Given this list of marker genes Nupr1, Foxl2, P2rx2, Mir669a-7, Akirin1, Mir669a-2, Shh, Ep300, Prkaa1, Cntnap1, Pax5, Fos, Nr2f2, Hdac4, Ppif, Mef2d, Eln, Mir669a-10, Shox2, Klf5, Ankrd2, Gpc1, Gtf3c5, Mir669a-4, Tbx1, Cyp26b1, Fxr1, Cited2, Des, Tgfb1, Rtl1, Synb, Hivep3, Nf1, Bmal1, Uqcc2, Dmrta2, Pax7, Vax1, Dag1, Myh14, Gmppa, Gm34220, Ccnt2, Vamp5, Myl6b, Rcan1, Mymx, Srpk3, Tll2, Lemd3, Bves, Notch1, Sox11, Phox2b, Cntfr, Vps54, Mylk2, Hlx, Pitx2, Bin3, Svil, B4galnt2, Myhas, Kras, Mir675 (NCBI Gene Id 735280), Ddx17, Hmg20b, Fbxo22, Asnsd1, Ldha, Lmod3, Rbfox1, Lncpint, Nr4a1, Pdlim3, Wnt10b, Psma6, Mylpf, Mapk14, Ephb1, Bcl9l, Negr1, Crhr2, Twist1, Ankrd33, Maff, Sap30, Snhg15, Casq1, Bcl9, Mir214, Atf3, Homer1, Wt1, Gata4, Met (NCBI Gene Id 194383), Popdc3, Sin3b, Emd, Dmd (NCBI Gene Id 93863), Nfix, Myl6, Xk, Cacna1s, Flot1, Mettl8, Usp19, Nras, Cdon, Smyd1, Col6a1, Rps6kb1, Fgfrl1, Scx, Gpx1, Klhl41, Nfatc3, Ddx5, Ero1a, S100b, Rb1, Nln, Hmgcr, Myom1, Pax3, Mir669a-6, Spg11, Tafazzin, Mir669a-8, Scn11a, Ybx3, Hoxd9, Cntnap2, Ppp3cb, Abcc9 (ATP-binding cassette, sub-family C member 9), Fkrp, Mcub, Hlf, Gpcpd1, Popdc2, Meox2, Dll1, Megf10, Myod1, Large1, Cdk5, Ryr1, Tcf7l2, Myt1, Asb2, Pitx1 (paired-like homeodomain transcription factor 1), Norad, Skil, Actn3, Rbm24, Lemd2, Plagl1, Snw1, Nr1d2, Cav2, Zfp689, Ppp3ca, Myc, Vgll2, Stra6, Myoz1, Msc, Btg2, Wnt3a, Selenon, Mir669a-3, Fktn, Chrnd, Igf2, Mtm1, Kat8, Myog, Cfl2, Bcl2, Ass1, Egr1, Myf5, Vrk3, Mir669a-5, Cops2, Kel, Klhl40, Flnb, Dner, Ski, Chrna1, Mettl21c, Cflar, Hspa8, Acta1, Hdac5, Myoz2, Hsd17b1 (hydroxysteroid (17-beta) dehydrogenase 1), Myorg, Myf6, Mir669a-1, Nphs1, Tcf21, Mbnl1, Foxp1, Foxp2, Barx2, Hoxd10, Adrb2, Pmp22, Ankrd1, Myocd, Egr2, Neurl1a, Hottip, Six1, Disp1, Smo, Heyl, Ctnnb1, Zbtb18, Eomes, Six4, Stac3, Med20, Foxn2, Mef2c, Cav1, Sox8, Mnx1, Hdac9, Col19a1, Plec, Mir669a-9, Meg3, Rhoa, Mstn, Usp2, here is a description of the gene set: Mouse Gene Set: GOBP_SKELETAL_MUSCLE_ORGAN_DEVELOPMENT species: Mus musculus The progression of a skeletal muscle organ over time from its initial formation to its mature state. A skeletal muscle organ includes the skeletal muscle tissue and its associated connective tissue.